The following is a description of a gene set: species: Homo sapiens from publication Chen Y, Wang X (PMID 31504780) Human Gene Set: MIR623 Genes predicted to be targets of miRBase v22 microRNA hsa-miR-623 in miRDB v6.0 with MirTarget v4 prediction scores > 80 (high confidence targets)., and this is the list of marker genes: SMIM13, CREB5, TTYH1, HAS2, CIPC, HAL, ZC3H7A, HYCC1, FRAS1, FOXC1, CRHBP, LSAMP, DNAJC13, EPHB2, EPHA7, ZZZ3, TMEM213, WDFY2, LDLRAD4, UBA6, ACSM2A, TOR1B, TMEM156, FBN2, EVC2, RHOBTB3, UBQLN1, TMEM134, BIRC2, COX5A, TRMT13, TCF12, ELAVL2, SRSF12, BIRC6, ANGPT1, KCNQ3, PPM1K, HOOK3, ATXN7, RETSAT, VAPB, PKM, ZNF549 (zinc finger protein 549), SLC37A3, NUDT7, WWC3, YPEL2, RBM24, IGFBP5, GPR19, MFSD11, FOXN2, PTPRD, M6PR, TFAP2A, TMED4, IKZF2, DCN, NR3C1, FAM210A, SEPTIN11, AP1S2, CACNA1C, ESRRG, HMGCR, ITPR1, CD163, JAK3, TRIM44, DLGAP5, GLIS3, NOP58, SCML1, SMIM14, RIMS2, CHST15, EPHB6 (NCBI Gene Id 2051), MLXIP, SH3PXD2A, SREK1, QSOX2, TAOK1 (NCBI Gene Id 80214), BBS7, NCOA7, PHF6, SLC16A6, PI4KB, ACSL4, AP3M2 (NCBI Gene Id 10947), FRS2, TMEM132C, SEC24D, C2orf68, NMT1, SKI, KLF3, RAB22A, NBR1, AP2A2, BRF1, MTMR7, SLC12A2, GPBP1L1, MEIS2, TMEM178B, CFAP418, CDK20, PCMT1, CCND2, CCDC117, SPRY3, ZNF197, SEMA5A (NCBI Gene Id 9037), ENOX2, HAPLN1, ZSWIM3, BICC1 (NCBI Gene Id 80114), ZCCHC24